Given this list of marker genes PIEZO1, RNF31, CCBE1, CD55, FAT4, here is a description of the gene set: Intestinal lymphangiectasia Human Gene Set: HP_INTESTINAL_LYMPHANGIECTASIA studied in species Homo sapiens Angiectasia of lymph vessels (i.e., dilatation of lymphatic vessels) in the intestines.